The following is a description of a gene set: The action of a molecule that contributes to the structural integrity of the extracellular matrix. Mouse Gene Set: GOMF_EXTRACELLULAR_MATRIX_STRUCTURAL_CONSTITUENT studied in species Mus musculus, and this is the list of marker genes: Otol1, Fras1, Tectb, Spock2, Mfge8, Aspn, Col4a4, Col24a1, Pxdn, Bgn, Reln, Lama5, Lama3, Col2a1, Col6a3 (collagen, type VI, alpha 3), Fgg, Lum (NCBI Gene Id 17022), Col6a1, Hspg2, Amelx, Col5a3, Ambn, Nid2, Col25a1, Dmbt1, Thbs4 (NCBI Gene Id 21828), Col4a3, Fn1, Col16a1, Col1a1, Col8a2, Postn, Col10a1, Col12a1, Zp2, Hmcn2, Fbn2, Zp1, Srpx2, Col1a2, Dpt, Igfbp6, Spon1, Mmrn1, Slit2, Col5a1, Col6a4, Igfbp7, Hapln1, Fbln5, Fbln1, Prelp, Col23a1, Matn2, Col18a1, Fgb (fibrinogen beta chain), Lamb2, Lamb3, Fbn1 (fibrillin 1), Col9a1, Sparc, Col22a1, Col4a1, Nid1, Npnt, Lama1, Zp3, Lama4, Ltbp4, Col19a1, Col6a5, Vtn, Col15a1, Col13a1 (NCBI Gene Id 12817), Mfap5, Col4a5, Efemp2, Col27a1, Marco, Col28a1 (NCBI Gene Id 635185), Agrn, Adipoq (adiponectin, C1Q and collagen domain containing), Prg2, Bmper, Vwa1, Ntn1, Mfap2, Eln, Lamc1, Col9a3, Col14a1, Muc2, Emilin1, Lamb1, Hapln4, Enam, Col6a6, Ltbp2, Col7a1 (collagen, type VII, alpha 1), Mfap1b, Col17a1, Comp, Mfap4, Ltbp1, Col6a2, Creld1, Ecm1, Dcn, Emilin2, Papln, Mfap1a, Tnc, Tinagl1, Col9a2, Sspo (NCBI Gene Id 97297), Hmcn1, Col4a2, Efemp1, Lamc2, Creld2, Emid1, Ogn, Col11a1, Tgfbi, Col4a6, Lama2, Col5a2, Mmrn2, Colq, Thbs1, Tecta, Scara3, Col8a1, Col3a1, Vwa5a, Fga, Vcan, Fbln2, Col11a2, Matn4, Pcolce2, Vwf